The following is a description of a gene set: Human Gene Set: GSE37533_PPARG1_FOXP3_VS_PPARG2_FOXP3_TRANSDUCED_CD4_TCELL_PIOGLITAZONE_TREATED_DN We identified Pparg as a major orchestrator of the phenotype of adipose-tissue resident regulatory T cells (VAT Tregs). To explore the contribution of Pparg1 and 2 in the generation of the VAT Tregs-specific gene signatures, CD4+FoxP3- T cells were transduced with Foxp3+/- Pparg1 (or Pparg2), treated with Pioglitazone or vehicle, and double sorted for microarray analysis. Genes down-regulated in CD4 T cells treated with pioglitazone and over-expressing: FOXP3 and PPARg1 isoform of PPARG versus FOXP3 and PPARg2 form of PPARG. from publication Cipolletta D, Feuerer M, Li A, Kamei N, Lee J, Shoelson SE, Benoist C, Mathis D (PMID 22722857) studied in species Homo sapiens, and this is the list of marker genes: ATP10D, BAZ1A, UBA7, PDE3A, MRTFB, FAT4, RAI14, STK3, DRAM1, PCDH7, USP15, TNFAIP2, SNRK, UBXN4, USP18, IRF9, BCL3, CALCOCO2, GCLM, IFI30, GVINP1, IFIT1, RCAN1, SOCS3, CASP7, IDO1, IRF8 (NCBI Gene Id 3394), MED21, OGFR, DDX60, AHCYL2, ZC3HAV1, NNMT, ATF3, FBXL7, VEGFC, ZNF267, STAT1, IFIT3, CYTH1, FKBP5, CMTR1, RTP4, DNAJA2, OAS3, POLR2H, SBNO2, SNTB2, ENY2, BCL6, PLA1A, CTRL, CD47, FOSL2, PSME2, SLFN12, RIGI, CASP1, TRIB2, FAM107A, NDUFA9, PSMB10, TANK, BAZ2A, XAF1, RIPK2, ADAR, CASP10, OAS1, SDAD1, DYRK4, FZD5, IFI44, LAP3, GCH1, PSMB8, TAP2, OAS2, SP100, PSME1 (proteasome activator subunit 1), PARP12, C5orf15, EIF2AK2, PDGFRA, TESK2, CSF1, DNAJB1, ACKR4, EDEM2, CLCN6, APOL6, SFT2D2, PPA1, IL12A (NCBI Gene Id 3592), NF1, TRIM21, PSMA4, SP110, SGCB, PKP4, TRIB1, HLA-B, AFF1, APOL2, APOL3, IFI35, VAMP5, TRANK1, IFITM1, JAK2, NMI, PRRG1, CXCL10, DYNLT1, SUSD6, CXCL9, UBR2 (ubiquitin protein ligase E3 component n-recognin 2), NDST2, BAK1, HLA-A (NCBI Gene Id 3105), ATP6V1B2, SLC25A28, IRF2, APOL1, STAT2, RSAD2, WARS1, MALT1, SECTM1, HDAC4, RNF19B, CBR3, TRAFD1, PHF11, VRK2, GBP1, CLIC2, PMAIP1, IFIT5, GBP2, IFIT2 (interferon induced protein with tetratricopeptide repeats 2), PML, HLA-F, ATP2A2, DNAJA1, TNFAIP1, PLSCR1, BTN3A1, SHFL, TLR3, CYLD, SP140L, ETV7 (NCBI Gene Id 51740), BCL2L13, TRIM14, CTDSP2, PSMB9, SIAH2, MCUB, ARID5A, MYD88, UBE2L6, IRF1, TNKS2, IFIH1, IL15RA, PLAAT4, TRIM22, LGALS9, SLC15A3, BACH1, BTN3A3, IFI44L, IL15, HERC6, SETBP1, EPB41L4A, MSRB1, FBXL14, TDRD7, ISG15, DDX23, RNF114 (ring finger protein 114), MX1, SCYL3, NREP, RAB27A (NCBI Gene Id 5873), AKAP8, ACSL5, SOCS1, TAP1, SETX, ART3, HLA-E, RIPK1, SAMHD1, FES, GOLM1, CXCL11